The following is a description of a gene set: studied in species Homo sapiens Human Gene Set: GOCC_IRON_SULFUR_CLUSTER_ASSEMBLY_COMPLEX A protein complex capable of assembling an iron-sulfur (Fe-S) cluster., and this is the list of marker genes: BOLA2B (NCBI Gene Id 654483), FXN, FDX2, ISCA2, LYRM4, CIAO2A, NFS1, CIAO3, BOLA2, GLRX5, MMS19, ISCA1, NDUFAB1, GLRX3, ISCU (NCBI Gene Id 91850), CIAO1, CIAO2B, BOLA1, BOLA3